The following is a description of a gene set: Reactome Pathway: Metabolism of amino acids and derivatives electronically inferred by orthology from the curated human pathway studied in species Mus musculus part of: Metabolism This event has been computationally inferred from an event that has been demonstrated in another species.<p>The inference is based on the homology mapping from PANTHER. Briefly, reactions for which all involved PhysicalEntities (in input, output and catalyst) have a mapped orthologue/paralogue (for complexes at least 75% of components must have a mapping) are inferred to the other species., and this is the list of marker genes: Bcat2, Got2, Psma7, Pnmt, Aldh9a1, Hal, Sat1, Otc, Slc44a2, Cav1, Psmb6, Ckb, Odc1, Slc6a7 (NCBI Gene Id 240332), Sds, Ido2, Duoxa1, Kynu, Pycr1, Hykk, Bckdhb, Dio1, Mpst, Psmc6, Dmgdh, Asns, Acadsb, Gadl1, Dio2, Psmd1, Oaz3, Psmc1 (NCBI Gene Id 19179), Aspa, Bcat1, Folh1, Aanat, Psmd12, Grhpr, Dld, Psmc5, Txnrd1, Duoxa2, Serinc4, Ckmt2, Slc25a2, Aadat, Ass1, Slc25a21, Hibadh, Suox, Hgd, Mri1, Oaz1, Mtap, Psma4, Psmc2, Psmb5, Hoga1, Iyd, Sephs2, Ddc, Dbh, Mccc2, Slc45a2, Slc25a10 (solute carrier family 25 (mitochondrial carrier, dicarboxylate transporter), member 10), Ftcd, Psmd7, Psma6 (NCBI Gene Id 26443), Ado, Pcbd1, Mrps36, Gls2, Naalad2, Psmd6, Glud1, Oaz2, Psma2, Carns1, Psmb7, Aspg, Slc3a2, Arg1, Th, Tyrp1, Dhtkd1, Fmo1, Psmb4, Slc36a4, Kmo, Tyr, Mtrr, Psma5, Srr (serine racemase), Gstz1, Psmc3, Ckm, Uroc1, Agmat, Carnmt1, Mat1a, Gamt, Psma3, Amdhd1, Ethe1, Tst, Dct, Amt, Rimkla, Hao1, Pycr2, Gpt, Oca2, Sardh, Hpd, Azin2, Psmd13, Nqo1, Dao, Pipox, Nmral1, Ido1 (NCBI Gene Id 15930), Aass, Bckdk, Pah, Gnmt, Tat, Dlst (dihydrolipoamide S-succinyltransferase), Got1, Arg2 (arginase type II), Cga, Rida, Phykpl, Psmc4, Oat, Crym, Slc25a13, Duox1, Tph1, Acad8, Asrgl1, Fah, Tpo, Psma1, Ckmt1